The following is a description of a gene set: studied in species Homo sapiens An anomaly of the surface of the nail. Human Gene Set: HP_ABNORMAL_NAIL_SURFACE Abnormal nail surface, and this is the list of marker genes: TINF2, ATP2A2, LPAR6, PEX1, ERCC3, EDAR, EFNB1, EDARADD, ERCC2, WNT5A, DKC1, PEX6, AQP5, FOXN1, KLK11, MPLKIP, GTF2H5, AIRE, SLC39A4, LMX1B, TP63, TARS1, DVL1, UFC1, WNT10A, HLA-C, GJA1, ATR, TERT, KRT14, RNF113A, MSX1, DVL3 (dishevelled segment polarity protein 3), IKBKG, CTSK, FERMT1, CARS1, PORCN, TERC, GTF2E2, FZD2, AARS1